The following is a description of a gene set: studied in species Homo sapiens Any process that stops, prevents or reduces the frequency, rate or extent of telomere maintenance via telomere lengthening. Human Gene Set: GOBP_NEGATIVE_REGULATION_OF_TELOMERE_MAINTENANCE_VIA_TELOMERE_LENGTHENING, and this is the list of marker genes: TENT4B, SLX4, PARP3, MCRS1, CTC1, XRN1, PINX1, NAT10, TP53, DCP2, TEN1 (TEN1 subunit of CST complex), POT1 (NCBI Gene Id 25913), HNRNPU, ACD, TERF1 (NCBI Gene Id 7013), HNRNPC, ERCC4, TNKS, EXOSC10, TERF2, PIF1, PML (NCBI Gene Id 5371), GNL3L (NCBI Gene Id 54552), TINF2, STN1, PARP1, SLX1A, TNKS2, SLX1B, HNRNPA1